The following is a description of a gene set: Binding to scavenger receptors, a family of proteins that are expressed on myeloid cells and are involved in the uptake of effete cellular components and foreign particles. Mouse Gene Set: GOMF_SCAVENGER_RECEPTOR_BINDING studied in species Mus musculus, and this is the list of marker genes: Pdzk1, Fpr3, Gba1, Fpr2, Fpr-rs7, Fpr-rs4, Fpr-rs6, Fpr1, Fpr-rs3